Given this list of marker genes ZNF99, HAGH, BCL2L13 (BCL2 like 13), ZSWIM3, FAM13A, NXT1, CADM3, VWDE, DNAJC25-GNG10, DMKN, GOLGA6C, PPP4R1, CPT1B, ATPAF1, FXYD6, SSR1, CD79A, GOLGA8T, CELF3 (NCBI Gene Id 11189), MAL2, ABCG4, FAM117A, INSIG1, IVD, MTMR11, ANKEF1, FAM107A, RAPGEFL1, TYR, HECW2, GOLGA8R (golgin A8 family member R), FUS, SOCS7, PAK5, ZBTB39, ZFAND5, ZNF135, MSI1, GOLGA8Q, RGCC, PDAP1, ZNF217, CBX7, GOLGA8J, C2orf68 (NCBI Gene Id 388969), MBNL2, CYBRD1 (cytochrome b reductase 1), FBXO41, FBXO11, C1orf162, ARID3B, EFNA2, FOXP2, PHF24, GNG10, CDK18, DR1, SRY, ENTPD2, KNG1, CTDSPL, USH2A, IQSEC2, BRCA1, PLAG1, here is a description of the gene set: Human Gene Set: MIR4446_3P from publication Chen Y, Wang X (PMID 31504780) Genes predicted to be targets of miRBase v22 microRNA hsa-miR-4446-3p in miRDB v6.0 with MirTarget v4 prediction scores > 80 (high confidence targets). species: Homo sapiens